The following is a description of a gene set: Human Gene Set: HP_FRAGMENTED_ELASTIC_FIBERS_IN_THE_DERMIS Elastic fibers in the dermis exhibit an increased number of breaks associated with disorganization of the structure of the elastic fibers. studied in species Homo sapiens Fragmented elastic fibers in the dermis, and this is the list of marker genes: ATP6V1A, CYP26C1, ALDH18A1, EFEMP2, FBLN5, LTBP1, ATP6V0A2, ATP6V1E1, ELN